Given this list of marker genes Tlr4, Park7, Foxo3, Adcy10, Grin1, Tlr6, Adgrb1, Slc5a3, Rab27a, Zfp13, Clcn3, Lcn2, Cd36, Sod2, Nox4, Plcg2, Il4, Duoxa1, Alox12, Ogt, Mfn2, Cyba, Hdac4, Duoxa2, here is a description of the gene set: Mouse Gene Set: GOBP_POSITIVE_REGULATION_OF_REACTIVE_OXYGEN_SPECIES_BIOSYNTHETIC_PROCESS studied in species Mus musculus Any process that activates or increases the frequency, rate or extent of reactive oxygen species biosynthetic process.